Given this list of marker genes UCP1, ADIPOQ, CRP, TFAP2A, PPARGC1A, SLC2A4, VEGFA, POMC, IL6, CDKN1A, VAMP2 (NCBI Gene Id 6844), CDKN1B, PPARG, KRT19, YAP1, INS, CDKN1C, CREB1, FOS, BCL2L11, PRKCD, here is a description of the gene set: Galanin receptor pathway Human Gene Set: WP_GALANIN_RECEPTOR_PATHWAY species: Homo sapiens